The following is a description of a gene set: studied in species Homo sapiens Human Gene Set: ZIC2_01 Genes having at least one occurrence of the motif KGGGTGGTC in the regions spanning 4 kb centered on their transcription starting sites. This matches the ZIC2 transcription factor binding site V$ZIC2_01 (v7.4 TRANSFAC)., and this is the list of marker genes: CA10, TRAF3IP2, NME3, PRX, KCNK3 (NCBI Gene Id 3777), TMEM132E-DT, PRKAG1, ZNF574, RPS6KA5, NDC80, HPCA, FBXW7, FSTL1, DLGAP4, DLL4 (NCBI Gene Id 54567), HOXB2, LRRTM3, ABR, PTCH2, SDCBP2, GRIN2D, GABRA1, HDDC3 (HD domain containing 3), RARG, FAM222B (NCBI Gene Id 55731), DAB1, EDN3, LRRTM1, ORC4, ERBB3 (NCBI Gene Id 619500), RAD52, DACT3, BECN1, TMEM132E, LAMC2, UBE2K (NCBI Gene Id 84819), OARD1, NFYA, MYCN, RNF167, FBRS, WDR82, NKX2-8, SEMA6C, CRYAB, ALKBH6, IRF9, MAPK10, CYP26B1, LMAN2L, DHRS3, BARHL1, CASKIN2, BBS1, HSPH1, PI4KB, CORO6, TENM1, MORF4L1, PKP4, PPP1R16B (protein phosphatase 1 regulatory subunit 16B), CRB2, PCGF2, MAP4, CSDE1, PURA, HR, LYST, H1-0, SOX12, DCTN3 (dynactin subunit 3), RAB6B, NLGN2, FNBP1, HOXA10, CTNNBIP1, CASZ1, DNAJB5, MLLT6, HOXD13, RAC1, ZNF462, KDM6A, GNAS, SPMIP6, FAXDC2, LRP8, MEGF8, KLHL5, NOL4, USP2, TMEM150A, DAAM1, PTCH1, CXXC5, NKX2-2, SCRT2, ZBTB32, DOLPP1, PI16, TRERF1, MPC2, GHR, SMOC1, MTUS1, REL, TMEM255A, CHRNB2, RIN1, RSF1, UBE2A, BAZ2A, ADAMTS1, RBBP6, KCNC1, MCRS1, HPX, ZNF384, SLC25A11, ETV6, RASSF2, SEMA3B, ANKRD13B, PRKCSH, CALR, FAM91A1 (NCBI Gene Id 157769), YARS1 (NCBI Gene Id 8565), CDK6, CADM2, GABRG2, LRRK1, TENT5A, PCDH10, KCNJ10, CD19, AMMECR1L (NCBI Gene Id 83607), ATP2C1, FLVCR2, MUSK, TSC22D4, NIPBL, DHX30, ZNF385A, GPM6A, FES, TIMP3, TOB2, KCND2, SYNCRIP, PPP2R5E, AAMDC, FOXP1, CCDC71L, CLDN6, CLTC, MACF1, TP53BP1, FGF20, GATA6, SOX15, PATL1, UNC45A, PAGR1, CA3, CA9, BDNF, EBP, CPNE1, RAB22A, YWHAG, HOXB8, ZCWPW1, NLGN3, PHF6, CYP26A1, MEA1, COL7A1, IL11, RAB11A, FANCD2, METTL4, OGT, ZMYM3, PIM1, DHX40, MARCHF7, TNNC2, ODAD3 (NCBI Gene Id 115948), WDR13, OSBPL2, MAP1A, TSSK2, NOG, NELL2, GPR85, CCDC148 (NCBI Gene Id 130940), OGG1, PDLIM2, IMPDH1, CERCAM, HOXB4 (homeobox B4), ZMYND8, AMDHD2, CALB1 (calbindin 1), LRP1, SFPQ, UTY, RAB1B, COL27A1, BAG6, CTNND1, ZFP36L1, CKB, RHO, TMEM196, PRDM10, RBM12, TGIF1, FASTK (NCBI Gene Id 80166, Fas activated serine/threonine kinase), PTPN1, TLK2, TRIM33, PLXDC2, SLC4A10 (NCBI Gene Id 57282), ZMYND11, IL17RC, TP53 (NCBI Gene Id 7157), HSPB2, HOXB9, MEPCE, SLC5A1 (solute carrier family 5 member 1), GLI1, FGF13, HEXIM2, PRMT1 (protein arginine methyltransferase 1), TLCD3B, KCNA1, PTK7, GNAO1, ZDHHC15, PHF12 (NCBI Gene Id 57649), ASB15, VCPIP1, DYNLL1, FGF12, WRAP53, UBALD2, EIF4A1 (NCBI Gene Id 1973), CBX6, SESN2, NTN3, NDUFA4L2